Given this list of marker genes Psmc5, Psmd1, Rab8a, Ccnh, Psma5, Dynll1, Tuba1b, Cep41, Wee1, Rps27a, Psma3, Tubb4a, Ccnb1, Psmb4, Tubb2b, Ccna1, Optn, E2f3, Sdccag8, Tubb6, Psmc1, Phlda1, Hjurp, Ticrr, Psmc6, Haus8, Psmc3, Ajuba, Psmb7, Psmd7, Ywhae, Ppp2r1b, Tuba1a, Trp53, Clasp1, Cdkn1a, E2f1, Sfi1, Nedd1, Ubb, Nde1, Prkaca, Cep131, Haus7, Xpo1, Fbxl7, Ninl, Mzt1, Cep152, Dctn1, Cep135, Plk1, Psmd13, Psmc4, Tubb4b, Fzr1, Haus5, Prkar2b, Tubgcp3, Psmd12, Hmmr, Cep192, Cdk11b, Psmb6, Cep72, Cul1, Obi1, Tuba3b, Csnk1e, Psma6, Tubgcp6, Cdc25c, Cep43, Bora, Psmb5, Psma1, Cep63, Psma4, Psmc2, Psma7, Cep57, Tuba8, Cenpj, Psma2, Haus1, Ppp2r2a, Tuba4a, Tpx2, Actr1a, Gtse1, Cdk1, Tubal3, Psmd6, Tubgcp2, Lcmt1, Ppme1, Fkbpl, Tuba1c, Cep290, here is a description of the gene set: Reactome Pathway: Mitotic G2-G2/M phases studied in species Mus musculus electronically inferred by orthology from the curated human pathway part of: Cell Cycle, Mitotic This event has been computationally inferred from an event that has been demonstrated in another species.<p>The inference is based on the homology mapping from PANTHER. Briefly, reactions for which all involved PhysicalEntities (in input, output and catalyst) have a mapped orthologue/paralogue (for complexes at least 75% of components must have a mapping) are inferred to the other species.